The following is a description of a gene set: studied in species Mus musculus Mouse Gene Set: REACTOME_INTERLEUKIN_2_FAMILY_SIGNALING Interleukin-2 family signaling, and this is the list of marker genes: Il2rb, Il3, Il15, Ptpn6, Il2, Il5ra, Il2rg, Pik3cd, Il21, Stat5b, Csf2rb2, Sos2, Stat3, Il5, Jak2, Pik3cb, Grb2, Stat5a (signal transducer and activator of transcription 5A), Inpp5d, Il9r, Csf2, Ptk2b, Pik3ca, Sos1, Pik3r2, Shc1, Syk, Il15ra, Il2ra, Il21r (NCBI Gene Id 60504), Il9 (interleukin 9), Pik3r3, Lck, Csf2rb, Inppl1, Pik3r1